The following is a description of a gene set: Human Gene Set: MIR6750_3P from publication Chen Y, Wang X (PMID 31504780) Genes predicted to be targets of miRBase v22 microRNA hsa-miR-6750-3p in miRDB v6.0 with MirTarget v4 prediction scores > 80 (high confidence targets). species: Homo sapiens, and this is the list of marker genes: RPEL1, PHF20L1, TULP4, SLC9A1, CFAP47, FNDC3A, GCH1, TMCC3, DNAJC25-GNG10, UQCC4, ERLIN2, UCHL3 (NCBI Gene Id 7347), UBE2G1, COPS7A, ATOH7, MAP1B, TMED7, EHBP1, CTBP2, PDE7B, CENPA, DTWD2, SMARCAD1, CHCHD2, STOX2, PTPRC, KCNA7, CDC14A, NRP2, PLCL1, PKDCC, EML6, SLITRK4, MPZL1, MED13L, ATXN7L3, DTL, TRIT1, KCNC2, TGFB2, CPA4, FYN, TRIM5, SEMA6D, RABGEF1 (NCBI Gene Id 27342), FAM199X, RGS5, PAXBP1, PPP2CA, C5orf15, MARK1, NUP160, GNG10, TMEM182, HDAC2, ADAMTS5, FAM241A, GPR158, PHAF1, ZPLD1, ZBTB4, PRDM10, PLAGL1, RPE, HPGD, LHX1, HEY1, CHD6